The following is a description of a gene set: studied in species Homo sapiens from publication Ioannidis I, McNally B, Willette M, Peeples ME, Chaussabel D, Durbin JE, Ramilo O, Mejias A, Flaño E (PMID 22398282) To study the transcriptional profile of patients with acute RSV or Influenza infection,children of median age 2.4 months (range 1.5-8.6) hospitalized with acute RSV and influenza virus infection were offered study enrollment after microbiologic confirmation of the diagnosis. Blood samples were collected from them within 42-72 hours of hospitalization. We excluded children with suspected or proven polymicrobial infections, with underlying chronic medical conditions (i.e congenital heart disease, renal insufficiency), with immunodeficiency, or those who received systemic steroids or other immunomodulatory therapies. The RSV cohort consisted of 51 patients with median age of 2 months (range 1.5-3.9) and the influenza cohort had 28 patients with median age of 5.5 months (range 1.4-21). Control samples were obtained from healthy children undergoing elective surgical procedures or at outpatient clinic visits. To exclude viral co-infections we performed nasopharyngeal viral cultures of all subjects. We recruited 10 control patients for the RSV cohort with median age of 6.7 months (range 5-10), and 12 control patients for the influenza cohort with median age of18.5 months (range 10.5-26). Genes down-regulated in comparison of peripheral blood mononuclear cells (PBMC) from healthy donors versus PBMCs from infanct with acute RSV infection. Human Gene Set: GSE34205_HEALTHY_VS_RSV_INF_INFANT_PBMC_DN, and this is the list of marker genes: MCM4, SLC4A1, CCNL1, BLVRB, SPAG5, TCN2, RBPMS, KLHL15, HPSE, SLPI, FAM53C, CEACAM6, TRAF3IP2-AS1, UBE2C, ARF4, UQCRFS1, NDUFAF6 (NCBI Gene Id 137682), TMOD1, AMELX, ADM, STMN1, UBE2B, ZNF326, ABCC13, CTNNAL1, CDCA5, ARL8A, STRADB, LGALS1, SERINC2, TK1, S100A9, RAD51, ORM1, IFI27, CDKN3, CDCA7, TUBA1B (tubulin alpha 1b), MELK, KLHL2, ANK1 (NCBI Gene Id 286), HTR4 (NCBI Gene Id 3360), E2F8, ARG1, KRT1, MPP1, E2F2, RNASE3, HBBP1, MKI67 (NCBI Gene Id 4288), LDHA, RETN, MTHFD1L, CYSTM1 (NCBI Gene Id 84418), TTK, ANXA3, ASGR2, SLC9A8, MTARC1, CALM3, NME1, DYSF, RANBP9, LCN2, TUBA1C (tubulin alpha 1c), GSPT1, XK, BCL6, LDLR, FBXO7, CDC34, UHRF1, MPO, HBM, IL1RN, SLC6A8, TMEM184A, RHEB, CA1, KIF23, NKX3-2, LIMK2, HEPACAM2, GNG10, PGLYRP1, ALAS2, RIOK3, MCEMP1, MMP8, GPER1, NSUN3, TUBA1A, EXTL1, TAB3, SELENBP1, TEDC2, THUMPD2, GYPB, TNS1, LRRC2, SNCA, CDK1, RNF10, RNASE2, PLBD1, BNIP3L, NOP58, VSTM1, DEFA4, OSBP2, VCF1, S100A12, SLBP, SPC25 (NCBI Gene Id 57405), KLF1, SAT1, CCNE1, DSC2 (NCBI Gene Id 1824), RAB1A, TRMT5, CDC45, GPR84 (NCBI Gene Id 57098), HLX, PPM1A, PRTN3, TUBB3, S100A8, NCF4, HBD, DNAJC6, CD36, CAMP, FECH, STAG3 (STAG3 cohesin complex component), RAP1GAP, MKRN1, CENPU, BST1, GMPR, FOXM1, YOD1, TTC36, THBS3, CEACAM8, MYL4, MAP1LC3B, SMTN, DOCK8-AS1, GSG1, E2F1, HEMGN, PCLAF, H1-3, HP, MMP9, H1-0, EXOSC9, NECTIN2, MYADM, TMEM52B, ADIPOR1, H1-2, NRAS, ACSL1, PRELID3B, TRIB1, PPP4R2, ESPL1, S100P, CD177, UBALD2, HMGN2, GLRX5, HBQ1, KLK14, TYMS, BPGM, H2AC14, BAMBI, RMND5A, AHSP, IFITM3, TFDP1, FCGR1BP (NCBI Gene Id 440607), CENPN, SLC22A4, PIP5K1A, EPB42, GYPA (NCBI Gene Id 2993), PCGF5, DCAF12 (NCBI Gene Id 25853), GNA15, RPIA, LTF, H2AC13, TMEM167A, BPI, OLFM4, EIF1B, AGFG1